The following is a description of a gene set: Glucocortocoid-insensitive primary hyperaldosteronism species: Homo sapiens A form of primary hyperaldosteronism in which the overproduction of aldosterone cannot be suppressed by the administration of dexamethasone or similar glucocorticoids. Human Gene Set: HP_GLUCOCORTOCOID_INSENSITIVE_PRIMARY_HYPERALDOSTERONISM, and this is the list of marker genes: KCNJ5, SCNN1A, CLCN2, SCNN1G, SCNN1B